The following is a description of a gene set: species: Mus musculus Genes predicted to be targets of miRBase v22 microRNA mmu_miR_7211_5p in miRDB v6.0 with MirTarget v4 prediction scores > 80 (high confidence targets). Mouse Gene Set: MIR_7211_5P from publication Chen Y, Wang X (PMID 31504780), and this is the list of marker genes: Atg4d, Gucy1a2, Mtss2, Myo9a, Zfp65, Plekhm3, Hectd2, Tnrc6b, Ppp1r3c, Thoc1, Mcidas, Sema3d, Chac2, Slc2a9 (solute carrier family 2 (facilitated glucose transporter), member 9), Abhd15, Coa3, Rhobtb3, Klhl21 (NCBI Gene Id 72038), Mocs2, Arl5a, Mtarc1, Pigr, Fbxo45, Asb5, Ptges3, Fcgrt, Hoxb7, Thoc2, Cyp19a1 (NCBI Gene Id 13075), Dgkg, Spmip9, Nr3c2, Slc27a6, Fhip1b, Mboat2, Rps6, Tardbp, Tada2b, Sall3, Acadsb, Mageb18, Ttl, Nr0b2, Brd3, Mtap, Arcn1, Lrrtm2, Prkg1, Gria2, Fam177a2 (family with sequence similarity 177 member A2), Otud7b, Dpp10, Ephb6, Cd59a (NCBI Gene Id 98841), Cmtr2, Erbb4, Hs6st1, Rlig1, Wac, Zfp704, Iigp1, Tyw5, Ppp2r3a, Socs7, Amot, Myo10, Dscam, Slfn9, Rgs4, Zfhx3, Klhl14, Tet1, Zfp811, Kif18a, Frat1, Unc80, Trp63 (NCBI Gene Id 22061), Eif4h, Arhgap26, Nup50, S1pr5, Zmym2, Serpinb5, 1700129C05Rik, Pdgfrb, Fasn, Rnf4, Nrg3, Vav3, Pax9, Aebp2, Zpld1, Syde2, Cd28, Tmem255a, Snx13, Ago4, Cct8, Otc, Sp4, Gba1, Cflar, Nap1l1, Rxfp3, AI182371, Mtcl1, Zkscan8, Ttpa, Fam124a, Igfbp2, Rhoq, Igf2bp1, Oxsm, Nde1, Pfn2, Scn2b, Lce3f, Ppt1, Hapstr1, Erc2 (ELKS/RAB6-interacting/CAST family member 2), Id1, Irag1, Aff2, Fam177a, Aplnr, Bicd1, Mdfic, Gid4, Anp32a, Acer3, Dynlt5, Dalrd3, Stx16, Grhl3, Zfp975, Acap2, Chrdl1, Elavl4, Kalrn, Fam185a, Ildr2, Zfp827, Carhsp1, Dpp9, Naa50, Egflam, Nit1 (nitrilase 1), Mtfp1, Ebf4, Gm12185, Usp12